The following is a description of a gene set: Marker genes curated from the annotated cluster as represented in the Descartes Human Gene Expression During Development database. studied in species Homo sapiens Human Gene Set: DESCARTES_FETAL_HEART_ERYTHROBLASTS The gene expression program underlying the specification of human cell types is of fundamental interest. The study authors generated human cell atlases of gene expression and chromatin accessibility in fetal tissues. For gene expression, the study authors applied three-level combinatorial indexing to >110 samples representing 15 organs, ultimately profiling ~4 million single cells. The study authors leveraged the literature and other atlases to identify and annotate hundreds of cell types and subtypes, both within and across tissues. Our analyses focused on organ-specific specializations of broadly distributed cell types (such as blood, endothelial, and epithelial), sites of fetal erythropoiesis (which notably included the adrenal gland), and integration with mouse developmental atlases (such as conserved specification of blood cells). These data represent a rich resource for the exploration of in vivo human gene expression in diverse tissues and cell types. from publication Cao J, O'Day DR, Pliner HA, Kingsley PD, Deng M, Daza RM, Zager MA, Aldinger KA, Blecher-Gonen R, Zhang F, Spielmann M, Palis J, Doherty D, Steemers FJ, Glass IA, Trapnell C, Shendure J (PMID 33184181), and this is the list of marker genes: LINC02762, SCLY, TRIM47, HINT2 (histidine triad nucleotide binding protein 2), ACSS1, PLEKHG2, PGGHG, HBP1, CDT1, POM121, MTMR8, HMGA1, ZNF141, SLC46A1, NXT1, ORMDL1, CAT, ROGDI, NPRL3, SPPL2B, SULT1A1, GIMAP2, DGCR6L, ZNF583, GLRX5, TOX4, DHX40, AKR1A1, PRPS2, ZNF530, DDX3Y, POP4, DCP1B, CPOX, HDGF, SRSF1, HBM, EIF3B, RPL22L1, ORC2, BTBD6, CNGA1, CEP295, HBA2, SPTY2D1, SLC38A7, EMC4, AP1M1, RPL3, LYPLAL1, KDM1B, CRB1, OAT, CLK4, GSTO2, PIK3IP1, SRFBP1, KIFC1, PCK2, ERGIC3, TM2D3, SNHG25, RNF123, HSP90AA1, AIDA, POLR2H, SYF2, RFXANK, SPG21, ESCO1, ZC3H11A, ZSWIM4, PIEZO1, GPS2, SMPDL3B, HTATIP2, ALAS2, SLC35C2, FKTN, CDK1 (NCBI Gene Id 983), POLR1A, OR2L13, LEMD3, SLC18B1, ARRDC4, MRPL22, TBC1D24, GRK6, FAM210A, SMS, TCHP (trichoplein keratin filament binding), GRWD1, SDE2, GSPT2, BAP1, HBA1, PRELID3B, KLHL28, GYPC, MTIF3, PRIM1, STK26, NRSN2-AS1, WRNIP1, ANKRD49, CENPJ, MTCO2P12, MED1, DRAM1, P2RX6, CD40, C6orf47, BRCA2, KATNBL1, ABCD2 (NCBI Gene Id 225), ASPHD1, POLR1E, STX16, CAB39L, TMEM161A, TMCC2, SENP1, FBXW4, SNHG7, DDX39B, CENPW, ZIC2, PPP1R9B, SERTAD2, TMED8, TXLNGY, PRIM2, SNHG8, RSRC2, RB1CC1, SMARCD2, FAM178B, PDZD8, ASCC2, MAN2B1, CDK5RAP1, HBG1, FUT10, ZNF143, ZNF90, HBG2, BCORL1, MCUR1, SNRPA, EPB42, BRI3BP, PPIL1, ABCF1, PMPCB, PRC1, LINC02100, SLC66A2, ERMAP, BCL10, NAE1, TNFRSF10A, STMP1, EPDR1, ZNF714, MTHFD2 (methylenetetrahydrofolate dehydrogenase (NADP+ dependent) 2, methenyltetrahydrofolate cyclohydrolase), ATP9B, LCLAT1, SLC7A11, CLGN, GON7, ETFDH, TRIM22, L3MBTL1, WDTC1, FTL, NOB1, TESC, TRIP10, TJAP1, RHCE, ZNF629, PMM2, SLC22A4, DEAF1, C11orf54, TRMU, EIF4A2, GSDMD, HERPUD2 (NCBI Gene Id 64224), ARMH1, NIP7, TARBP1, AARS1, DYNLT2B, PGLS, EXPH5, METAP2, GATD1-DT, EIF2B1, HIC2, PAIP1, FCHO1, RBM33-DT, TBC1D10C, EIF1AD, CHCHD6, ASL, TAF6L, TBK1, KLC4, NEIL3, PTPA, ABCB7, POGLUT2, MTBP, ENPP4, RPIA, DBNL, INTS3, NHP2, SKA1, FARSA, MACROD1, STK11IP, NIFK, TIMELESS, OARD1, C6orf132, SPOUT1, UVSSA, S100P, MXI1, SLC35A2, METTL2A, HMGN1, UBQLN1, RAD54L2, NCAPG2, TRAK2, RRP1B, ARMC2 (NCBI Gene Id 84071), ADIPOR2, TMEM238, NAA10, APMAP, POLR3B, TRAM2, USP6NL, CHASERR, ACAD11, DDX39A, SNHG5 (NCBI Gene Id 387066), TRIM52, APEH, PI4K2B, PLAA, ZNF496, UBE3D, SLC2A1, LRRC47, KATNA1, BLVRB, CLTC (NCBI Gene Id 9511), ABCG2, BUD13, ME3, AMFR, NAT10, C7orf50, SELENOF, GET4, KRIT1, PRKAB1, GCC2, MIDEAS, SMC2, DHX35, ZDHHC7, RBM27, ZMIZ2, NAXE, SELENOH, USP38 (ubiquitin specific peptidase 38)